The following is a description of a gene set: Mouse Gene Set: GOBP_REGULATION_OF_GROWTH Any process that modulates the frequency, rate or extent of the growth of all or part of an organism so that it occurs at its proper speed, either globally or in a specific part of the organism's development. studied in species Mus musculus, and this is the list of marker genes: Pls1, Cdkn1a, Grn, Erbb4, Tgfb2, Epha7, Parp1, Gng4, Hpn, Myo5b, Serpine1, Rims2, Zfp639, Cdh1, Mycbp2, Commd5, Unc13a (unc-13 homolog A), Sash3, Bdkrb1, Stat5b, Uri1, Adam17 (NCBI Gene Id 236174), Slc6a4, Ing5, Slit1, Cda, Spart, Cdkn2a, Nrg1, Stk11, Bcl2, Trim40, Plxna4 (NCBI Gene Id 330281), Cdkn1b, Jarid2 (NCBI Gene Id 97879), Cxcl12, Mlst8, Rnd2, Lgi1, Pou4f2, Ptch1, Map2k5, Kif26a, Psrc1, Lin7a, Mad2l2, Sertad3, Gdf15, Cxcr4, Eif2b2, Ttc3, Foxc1 (NCBI Gene Id 17300), Zmat3, Hrg, App, Pin1, Barhl2, Bnipl, Pot1b, Flt4, Trpv2, Prkdc, Lamtor2, Exosc4, Plxna3, Socs6, Mmp14, Ncbp1, Hnrnpk, L1cam (NCBI Gene Id 16728), Mir467a-1, Sfrp1, Fn1, Mir208a, Crlf3, Hdac3, Hspa1b, Sod1, Fgf9, Dcaf1, Prox1, Vil1, Ryk, Wfs1, Rrad, Rasal1, Lin7b, Cdkn2c, Safb, Igfbp3, Fosl2, Hey2, Ppan, Musk, Cdkn2aip, Eno1b, Foxs1, Exosc9 (exosome component 9), Bdnf, Bcl11a, Mbd5, Supv3l1, Dcstamp, Mndal, Alms1, Mt1, Hopx, Ybx3, Kif14, Syt1, Csf2rb, Spag9, G6pdx, Sphk1, Cd44, Agt, Suv39h1, Smo, Tsg101, Mir155, Pum2, Col14a1, Cttn, Rab21, Cdkl5, Wwc1, Hamp, Wt1, Actn3, Rims1, Rps6kb1 (ribosomal protein S6 kinase, polypeptide 1), Mapk11, Alox8, P3h1, Mecp2, Acvrl1, Dact3, Tbx5, Sema3f, Igfbp1, Ppard, Plaa, Stc2, Spaar, Ccn3, Tle5, Rptor, Myocd, Fhl1, Hdac6, Cyba, Cacng7, Sema6d, Jade3, Cryab, Mael, Ihh, Pex5, Mir467a-2, Trp73 (NCBI Gene Id 22062), Armc12, Atad3a, Dusp6, Foxc2, Slc9a1, Arhgap32, P2rx5, Draxin, Atp8a2, Pnpt1, Igfbp4, Pou3f2, Mir467a-5, Agrn, Adnp, Erbb2, Fdps, Plaat1, Hsf1, Brat1, Ncor1, Avp, D7Ertd443e, Acsl4, Gpat4, Ncam1, Tbx2, Arx, Ntrk3, Plcb1 (phospholipase C, beta 1), Pten, Dcx, G6pd2, Pi16, Syt2, Cfl1, Lep, Gas1, Slc44a4, Drd3, Caprin2, Tomm70a, Gdi1, Efna5, Bst2, Cdk1, Cpne6, Anapc2, Ptk2, Wrn, Cdh4, Trp53, Tgfbr1, Tcf7l2, Nog, Hdgfl2 (HDGF like 2), Lin7c, Reg1, Hnf1b, Hdac2, Sgpl1, Ucn, Phip, Prdm11, Foxk1, Prdm4, Chd7, F2, Pim1 (NCBI Gene Id 18712), Ddr1, Pafah1b1, Myl2, Cntf, Tnks2, Ppib, Prkcb, Clasp2, Rgs4 (NCBI Gene Id 19736), Rack1, Ahsg, Ccr5, Golga4, Ppm1f, Pin1rt1, Krt17 (keratin 17), Nppb, Zfp418, Dnm2, Ahr, Rerg, Ngf, Bap1, Rftn1, Vps54, Bbs2, Tfcp2l1, Pml, Daxx, Ceacam1, Mir467a-3, Tbx1, Trip10, Ep300, Azgp1, Bbc3, Macf1, Ncoa3, Fto, Ccnb1, Tnc, Mgll, Hnf4a, Plac8, Ndufa13, Meaf6, Cth, Rufy3, Map3k13, Opa3, Insr, Islr2, Clstn3, Bmp10, Ing4, Cxadr, Gja1, Rtn4, Ahi1, Mtpn, Smad7, Ccnd2, Psmd10, Twf2, Cyfip1, Cav3, Picalm, Il9, Mir1a-2, Dab2ip, Clstn1 (NCBI Gene Id 74323), Igf1, Sox17, Gsk3b, Sirt1, Selenop, Gjd4, Dbn1, Il7, Flt3, Six1, Cited2, H3f5, Agr2, Mapt, Apc, Kdm2b, Drd2, Rhoa, Rgma, Sox15, Cpne5, Slc25a33, Hsd3b7, Rag2, Nr3c1, Tead1, Men1, Lats1, Lgmn, Rbpj, Mapk14, Ptk6, Atg16l1, Fgfr1, Ppp1r9b, Tgfb1, Parp2, D1Pas1, Tmprss11d, Sh3glb1, Ist1, Adrb3, Dcun1d5, Kcnk2, Ino80, Fgf13, Wdr36, Mapk1, Gdf9, Sema5a, Adcy10, Adrb1, Rb1, Ntn1, Slc6a3, Mir675, Mir467a-7, Cep43, Wnt2, Sdcbp, Zc3h12d, Ccn5, Adam10, Tmprss4, Ttl, Crk, Tbx20, Fgf20, Lats2, Igfbp7, Gli1, Megf8, Disc1, Syt17, Wfdc1, Nf2, Afdn, Pabir1, Bcl2l11, Fam107a, Hbegf, Npm1, Mir467a-4, Dyrk1a, Cdkn2d, Slit3, Spr, Sphk2, Mapkap1, Mul1, Tll2, Xbp1, Zfp640, Adam15, C3, Dspp, Ppara, Tshr (thyroid stimulating hormone receptor), Dlg1, Myoz1 (NCBI Gene Id 80553), Nppa, Nkx2-5, Ccar2, Ei24, Dscam, Tgfbr3, Cdhr2, Sema3a, Jade2, Myh6, Wnt3a, Sgk1, Pak1, Stk4, Smarca2, Flvcr1, Egfr, Crabp2 (NCBI Gene Id 99759), Ccdc85b, Htra2, Eif4g2 (NCBI Gene Id 77989), Acacb, Mir467a-10, Mtm1, Hmga2, Cdc73, Eif4g1, Siah1a, Smurf1, Fstl4, Zfyve27, Sertad1, Hspa1a, Afg3l2, Tnk1, Smad3, Stk3, Exosc2, Colq, Syt3, Ndufs3, Ceacam2, Sgip1, Tkt, Slc23a2, Tspyl2, Nrp1, Gata4, Gdf2, Ghsr, Usp47, Ostn, Gap43, Bltp1, Dll1, Il3, Smarca4, Eno1, Cgref1, Sbf1, Frzb, Adipor2, Creb3, Omg, Ccn4, Yap1, Zp3, Cga, Mir133a-2, Dnajb2, Akap6, Tnfrsf12a, Socs2, Serpine2, Edn1, Cgrrf1, Zpr1, Gpr21 (G protein-coupled receptor 21), Fbp1, Mag, Ghrh, Tgfbr2, Ptprs, Avpr1a, Prr5, Gpc3, Ros1, Map1b, Sptbn4, Ptger4, Hamp2, Apoe (apolipoprotein E), Jade1, Adrb2, Pparg, Dcbld2, Epm2a, Klhl22, Nipbl (NCBI Gene Id 97967), Eaf2, Ip6k2, Rbm10, Fgf2, Sin3a (NCBI Gene Id 20466), Ilk, Gpam, Actr3, Zmpste24, Atxn2, Csf1, Wnt5a, Derl2, Vgll4, Cacna2d2, Sfrp2, Ddx39b, Nppc, Bbs4, Rictor, Vegfa, Ptch2, Nkx6-1, Mkks, Celf1, Acvr1b, Armc10, Ulk1, Rai1, Cirbp, Ddx3x, Shtn1, Cyp27b1, Mt3, Mfsd2a, Ndel1, Mef2c, Cdk5, Dcun1d3, Fgfr2, Ulk2, Bcl2l1, Slit2, Sema6c, Dip2b, Cd38, Nedd4l, Osgin2, Cryaa (crystallin, alpha A), Zfpm2, Pttg1, Dnph1, Six4, Crkl, Pdzd11 (NCBI Gene Id 72621), Ddx49, Mir133a-1 (microRNA 133a-1), Ar, Slc25a4, Tchp, Abl1, Akt1, Fgfr3, Syt4, Nanos1, Foxp1, Dbnl (drebrin-like), Gnas, Igf2, Stat5a, Gamt, Mt2, Kazald1, Cacna1c, Npy1r, Mtor, Stat3, Trim46, Osgin1, Phb1, Brca1, Igf1r, H19, Ankrd26, Extl3, Rtn4r, Sesn1, Lrp1, Mir467a-6, Sfn, Rnf6, Mir467a-9, Wwc2, Ccnb2, Sesn2, Fxn, N6amt1, Grem1, Nme6, Lmx1a, Enpp1, Sh3bp4, Inhba (NCBI Gene Id 16323), Ifrd1, Olfm1, Rpl4, Sav1, Taf9b, Tmem196, Nell2, Bmpr2, Cdkl3, Map2, Wnt11, Srf, Pou1f1, Smad4, Notch1, Dio3, Minar1, Lpar3, Prlh, Lamtor1, Ctdp1, Cdc42, Rgs2, Ikzf1 (IKAROS family zinc finger 1), Ptprj, Creb1, Rbbp7, Ptk2b, Fgf8, Limk1, Dab2, Sema7a, Hyal1, Gh, Cxcl16, Mir21a, Prkn, Wnt3, Bmpr1a, Ppt1, Csnk2a1, Igfbpl1, Sertad2, Sema4f, Il9r, Sema3g, Tnr, Dnajc2, Atrn, Hif1a, Gata6 (GATA binding protein 6), Uts2r, Itsn2, Trpc5, Pik3ca, Rnf157, Hoxb13, Yy1, Dusp10, Hlx, Hyal2, Mstn, Bcl6, Gsk3a, Serp1, Kat7, Msx1, D130043K22Rik, Cpne9, Myod1, Gdf5, Cib1, Ghr, Naif1, Sh3pxd2b, Eppk1, Ezr, Ghrl, Nubp1, Rbp4, St7l, Sema4d, Capn3, Trim32, Ghrhr, Tro, Arhgap4, Igfbp5, Adipor1 (NCBI Gene Id 72674), Mir467a-8